Given this list of marker genes Mrto4, Dad1, Ass1, Ppia, Tmem147, Cycs, Cct5, Rpn2, Hnrnpa1, Bcap29, Zap70, Pgk1, Nudc, Lsm7, Srm, Dgat1, Xbp1, Ebna1bp2, Arpc1b, Hspa9, Smox, Eif4g1, Psme2, Prdx1, Srsf9, Naa20, Abcf1, Tomm5, Npm3, Psma4, Snu13, Tmed2, Banf1 (BAF nuclear assembly factor 1), Sar1a, Cyb5a, Il1r1, Rrs1, Timm8a1, Srsf10, Gar1, Gngt2, Dcun1d5, Anp32b, Tasp1, Serpinb1a, Aen, Ndufb6, Ptma, C1qbp, Ndufaf4, Prpf31, Aprt, Id2, Pdia3, Cdk2ap2, Ciao2a, Atad3a (ATPase family, AAA domain containing 3A, NCBI Gene Id 71964), Atp5mc1, Anp32e, Cct3, Sema4a, Uqcc2 (NCBI Gene Id 67267), Cetn3, Tmed9, Ubl4a, Ddost, Ecd, Mybbp1a (NCBI Gene Id 18432), Kars1 (NCBI Gene Id 85305), Taf10, Tubb4b, Cfl1, Bhlhe40, Nhp2, Espn, Cytip, U2af1, Fbl, Smyd2, Arl6ip5, Ndufs4, Odc1, Ptges3, Eloc, Hsp90aa1, Hnrnpa2b1, Lpcat3, Sars1, Chrac1, Ccr2, Srsf3, Pycr3, Vsir, Psma2, Hnrnpd, Denr, Ahr, Ywhae, Cish, Hspd1, Bst2 (NCBI Gene Id 97478), Socs1, Pgam1, Hspa5, Cabin1, Ubap2, Myd88, Atp1a1, Lman2, Ccdc86 (coiled-coil domain containing 86), Rrp1b, Srsf2, Gspt1, Elob, Erh (ERH mRNA splicing and mitosis factor), Sbno2, Psmd7, Wdr83os, Ddx39a, Slc25a5, Fkbp2, Ndufa5, Ndufb4, Gtpbp4, Ufm1, Hspa8 (NCBI Gene Id 69197), Luzp1, Hnrnpu, Nabp1, Lsm6, Kpnb1, Cnbp (cellular nucleic acid binding protein), Ran, Avpi1, Psmd8 (NCBI Gene Id 99154), Phb1, Tmed5, Sdf2l1, Eif1a, Blk, Eif3c, Tle3, Tpm3, Rbm3, Srp9, Psmb4, Nolc1, Utp18, Arhgdia, Eif1ax, Snrpd1, Cyb5b, Gapdh, Npm1, Eprs1, Sub1, Nars1, Mbd3, Hsp90b1, Tuba1b, Cdv3, Batf, Psmd1, Socs3, Thrap3 (thyroid hormone receptor associated protein 3), Calr, Snrpa, Septin11, Gemin5, Snrpf, Nsun2 (NCBI Gene Id 28114), Morf4l2, Manf (mesencephalic astrocyte-derived neurotrophic factor), Pim1, Ost4 (oligosaccharyltransferase complex subunit 4 (non-catalytic)), Nifk, Cap1, Mapkapk2, Ppp1r14b, Cct8, Gnb1, Hdgf, Stt3b, Ndufb2, Epop, Golt1b, Hspa4 (NCBI Gene Id 15525, heat shock protein 4), Arl4c, Psmb7, Degs1, Psme1 (NCBI Gene Id 19186), Hsp90ab1, Mat2a, Eif4a1, Cox5a, Krtcap2, Surf4, Ldha, Soat1, F2rl2, Rexo2, Rsl1d1, Ppib, Ly6a, Il22, Hnrnpk, Smc5, Mrpl12, Larp1, Mrps28, Mydgf, Phf5a, Pfn1, Ranbp1, Ffar2, Comt, Dkc1, Gzmb (NCBI Gene Id 14939), Ppa1, Ncl, Rrp1, Bclaf1 (NCBI Gene Id 72567), Pak1ip1, Set, Pde5a (NCBI Gene Id 242202), Gadd45g, Hnrnph2, Rcl1, Bax, Ssbp4, Prmt1, Pdia4, Alkbh1, Ddx21, Trmt1, Serbp1, Eif3a, Impdh2, Atp5f1d, Hmgcr, Fam162a, Strap, Nme2 (NME/NM23 nucleoside diphosphate kinase 2), Mthfd2, Sumo2, Furin, Chmp4b, Cd82 (NCBI Gene Id 99148), Tmem14c, Cdk2ap1, P4hb, Igf2r, Alyref, Dnajb11, Fabp5, Atic, Yrdc, Snrpd3, Vmp1, Pdia6, Apex1, Pa2g4, Acaca, Il2rb (interleukin 2 receptor, beta chain), Tsr1, Eif3b, Hyou1, Dctpp1, Eif2s2, Sap18, Snrpa1, Mettl1, Cct4, Zfp593, Hnrnpa3, Atp5mc3, Dnaja2, Caprin1, Rars1, Tnfrsf25, Nop56, Srgap3, Spcs3, Eif5a, Lat, Runx1, Rad23b, Ubxn4, Emc6, Ube2m, Cyfip2, Sf1, G3bp1, Utp3, Aurkaip1, Smarcc1, Cltb, Adam19, Eif1, Hnrnpab, Creld2, Ndufab1, Blm, Cox6a1, Tubb5, Sf3b6, Ranbp2, S100a11, Camk2d, Ybx1, Chd1, Agpat5, Nme1, Sdhd, Gnl3 (guanine nucleotide binding protein nucleolar 3), Chchd1, Atp5pb, Atf6, Ssr4 (NCBI Gene Id 97594), Mdn1, Gpatch4, Pus7, Mif, Hprt1, Gars1, Psmd11, Llph (NCBI Gene Id 66225), Cdkn2d, Psmd3, Rpn1, Eif5b, Ptpn1, St13, Usp5, Mmadhc, Cpd, Usp36, Pals2, Abi3, Ola1, Commd3, Bcl3, Ube2l3, Canx, Erap1, Nop58, Crlf2, Stat3, Mrps17 (NCBI Gene Id 66258), Cysltr2, Txn2, Psenen, Ruvbl1, Lamp2, F2r, Pcbp1, here is a description of the gene set: from publication Cui A, Huang T, Li S, Ma A, Pérez JL, Sander C, Keskin DB, Wu CJ, Fraenkel E, Hacohen N (PMID 38057668) Mouse Gene Set: CUI_T_CELL_GD_IL23_RESPONSE_UP species: Mus musculus Cytokines mediate cell-cell communication in the immune system and represent important therapeutic targets. A myriad of studies have highlighted their central role in immune function, yet we lack a global view of the cellular responses of each immune cell type to each cytokine. To address this gap, the authors created the Immune Dictionary, a compendium of single-cell transcriptomic profiles of more than 17 immune cell types in response to each of 86 cytokines (>1,400 cytokine-cell type combinations) in mouse lymph nodes in vivo. A cytokine-centric view of the dictionary revealed that most cytokines induce highly cell-type-specific responses. For example, the inflammatory cytokine interleukin-1β induces distinct gene programmes in almost every cell type. A cell-type-centric view of the dictionary identified more than 66 cytokine-driven cellular polarization states across immune cell types, including previously uncharacterized states such as an interleukin-18-induced polyfunctional natural killer cell state. Genes positively differentially expressed in cell type: γδ T cell upon treatment with cytokine: IL-23 in mouse lymph nodes in vivo.